The following is a description of a gene set: Mouse Gene Set: GOBP_SPONTANEOUS_SYNAPTIC_TRANSMISSION species: Mus musculus The low level of synaptic transmission that occurs via spontaneous neurotransmitter release into the synaptic cleft in the absence of a presynaptic action potential., and this is the list of marker genes: App, Unc13b, Doc2g, Rims1, Prkn, Doc2a, Cbln2, Rph3a, Itgb1, Syt1, Stx1b, Ager, Ppp1r9a, Rims2, Nsg1, Doc2b, Slc12a2